Given this list of marker genes PPP2R5E, PPP2CA, GSK3B, APC (NCBI Gene Id 324), PPP2R5B, PPP2R1B, PPP2R5A, AMER1, PPP2R5C, PPP2R1A, CSNK1A1 (NCBI Gene Id 55416), PPP2R5D, AXIN1, PPP2CB, here is a description of the gene set: Alterations in AXIN1 have been detected in a number of different cancers including liver and colorectal cancer and medullablastoma, among others. Missense and nonsense mutations that disrupt or remove protein-protein interaction domains are common, and AXIN variants in cancers tend to disrupt the formation of a functional destruction complex. species: Homo sapiens Reactome Pathway: AXIN missense mutants destabilize the destruction complex part of: Signaling by AXIN mutants